The following is a description of a gene set: species: Homo sapiens Genes up-regulated in comparison of peripheral blood mononuclear cells (PBMC) from patients with type 1 diabetes at the time of the diagnosis versus those at 4 months later. Objective: We hypothesized that type 1 diabetes (T1D) is accompanied by changes in gene expression in peripheral blood mononuclear cells (PBMCs) due to dysregulation of adaptive and innate immunity, counterregulatory responses to immune dysregulation, insulin deficiency and hyperglycemia. Research Design and Methods: Microarray analysis was performed on PBMCs from 43 patients with newly diagnosed T1D, 12 patients with newly diagnosed type 2 diabetes (T2D) and 24 healthy controls. One and four month follow-up samples were obtained from 20 of the T1D patients. Results: Microarray analysis identified genes differing in expression between newlydiagnosed T1D patients and controls at a false discovery rate of 0.05. Changes in expression of interleukin-1β (IL1B), early growth response gene 3 (EGR3), and prostaglandin-endoperoxide synthase 2 (PTGS2) resolved within four months of insulin therapy and were also observed in T2D suggesting that they resulted from hyperglycemia. With use of a knowledge base, 81/genes could be placed within a network of interrelated genes with predicted functions including apoptosis and cell proliferation. IL1B and the MYC oncogene were the most highly-connected genes in the network. IL1B was highly overexpressed in both T1D and T2D, whereas MYC was dysregulated only in T1D. Conclusion: T1D and T2D likely share a final common pathway for beta cell dysfunction that includes secretion of interleukin-1β and prostaglandins by immune effector cells, exacerbating existing beta cell dysfunction, and causing further hyperglycemia. The results identify several targets for disease-modifying therapy of diabetes and potential biomarkers for monitoring treatment efficacy. from publication Kaizer EC, Glaser CL, Chaussabel D, Banchereau J, Pascual V, White PC (PMID 17595242) Human Gene Set: GSE9006_TYPE_1_DIABETES_AT_DX_VS_4MONTH_POST_DX_PBMC_UP, and this is the list of marker genes: NADSYN1, PRPF6, ALDOA, NECAP1, NPTN, APOBEC3A, YWHAZ, GLG1, CEACAM8, MAPK6, RBM3, PUF60, KDELR2, P4HB, PFKFB3, RPN1, EHD4 (NCBI Gene Id 30844), TP53BP2, HNRNPA1, ID1, HSPA5, ELANE, FPR2, G0S2, NSD1, IL1R1 (NCBI Gene Id 3554), GMPS, SLC30A9, IBTK, PPIF, JUNB, SFN, TPD52L2, SAFB2, NOC2L, ARF6, CTSD, TNFAIP3, SAFB, COPS7B, DDX3X, P2RY2, SIK1, ADM, PHF21A, GBA1LP (glucosylceramidase beta 1 like, pseudogene), FPR1, SAT1, LAPTM5, MAPK1IP1L (NCBI Gene Id 93487), NFKBIA, FOSB, COPG1, IER2, ZFP36, CXCL2, RNF19B, BAG5, UQCRC1, ZFP36L1, NFKB2, DHCR7, PLK3, NDUFV1, PDIA4, HNRNPH2, TUBA3D, RTN3, ODF2, CKAP4, GPAA1, GUSB, VASP, PPP1R15A, NUDT18, SFPQ, TSC22D3, AQP9, GLUD1, FZR1, DDIT4, DUSP5, EGR3, HNRNPK, AMDHD2, HNRNPA3, LSM12, PLEKHO2 (pleckstrin homology domain containing O2), AAMP, HNRNPU, SPATA2L, RAB8A, GLUL, RETREG2, PAF1, SLC2A3, ACTR2, PTX3, ATP6V0D1, UPP1, AREG, RAB1B, GPI, BLK, POTEKP, PRCC, NR4A2, IVNS1ABP, DUSP1, PABPC4, CYBB, KIAA0930, TSR3, PRMT7, AZU1, PAK2, NAMPT, PDIA3, HMGB2, QSOX1, STX11, EREG, MAPRE1, CDC37, FCAR, THOC6, EIF4ENIF1, SGTA, JUND, CTSZ, BNIP2, TNFRSF14, ZNF394, HYOU1, MFSD10, CD83, SRSF9 (NCBI Gene Id 8683), SGK1, TSPAN14, RGS1, WDR18, TESK2, RRP12, MRPL12, COTL1, CDK9, PPP4C, ARL4A, CXCR4, G3BP2 (G3BP stress granule assembly factor 2), CIRBP, MGAM, SIL1, TREM1, SCPEP1, FFAR2, S100P, CHFR, REX1BD, SNF8, SART1, GNAI3, NFIL3, MARCKS, HSPA9, WIPI2, NUP93, BHLHE40, TRIB1, MAFB, ARHGAP26, PTPRA, ATP6V0A1, SOCS1, CDT1, GSN, PIGA, ZBTB17, PSMD13, HBEGF, TYMP, APOBR, CREM, SOCS3, ELMO1, HP, TCIRG1, MINK1, HERPUD1, MCL1, ADNP2, CARS2, CCDC22, IL1B, ILVBL, UAP1 (NCBI Gene Id 6675), ICAM3, BCL6, SCO2, WDR70